Given this list of marker genes NUDT21, ACSBG1, RBM34, MMD, CLK4, CCNB1IP1, VAMP7, LINC01011, PHIP, H2AC6, ANKRD13A, PURA, PTMA, DHX29 (DExH-box helicase 29), UBE2D2, XK, PPP4R3B, GPR160, ABCE1, SNORD33, ERH, ZBTB4, GTSCR1, CLEC2D, UBP1, SH3BGRL2, HECA, SOX4, RBM27, TMEM123, HIGD1A, ARL6IP5, UBE2V2, NELL2, CCDC65, DLEU1, ANAPC16, CYP4V2, CORO1C, STAP1, H2BC21, DOCK11, CBFB, ECHDC1, ANKRD46, ZC3H11B, ZBTB8OS, C1orf198, HPF1, CHSY1, TLK1, MTPN, KLHL9, DIAPH2, OSBPL11, CFAP36, SNORD62B, MTF2, ARB2A, NUCKS1, CREBRF, PIGY, RNF11, DENR, STRADB, PSMA3, PAIP2, NKRF, TBPL1, DEK (NCBI Gene Id 7913), NRGN, RDH11, AQP10, FBXO33, ATP9A, ANKRD12, PTPN22, FAXDC2, MRPL42, TC2N (tandem C2 domains, nuclear), CEP20, PPP1R2, CAVIN2, ING3, RNF138, MPL, MEX3C, C2orf88, OPTN, TMEM14B, NT5M, MRPS28, ITGAE, INPP4B, RGS18 (NCBI Gene Id 92122), MTDH, FEZ2, RNASEH2B, CDKN2AIP, H2BC11, CELA1, IRF2BP2, GYPC, TOMM7, SPAST, ANAPC10, HSD17B12, AMD1, CABP5, ALOX12, CPD, ARFIP1, RGS10, ATG5, NAP1L1, MRPL3, IDI1, COPG2 (NCBI Gene Id 80038), COPS8, YPEL5, METTL23, MTURN, ARPC5, PCMT1, GUCY1A1, ANTXR2, PGRMC1, DIPK2A (NCBI Gene Id 205428), YEATS4, NDUFV2, RTRAF, ALG6, SNORD32A, ITGB5, MTX2, MFSD6, CTDSPL, TREML1, H3C10, PLEKHA8P1, GASK1B, LAX1, C1GALT1C1, RAD21, DYNLL1, OSTM1, PLCL2, TBC1D15, G3BP1, RPL15, YIPF4, SRBD1, MRPL21, PTPN12, CDV3, NMD3, LAPTM4B, PIK3R1, TMEM126A, SRSF1, TPM1, BCLAF1, RYBP, COPB1, TMEM158, BBOF1, GMPR, HBD, SLC39A8, HMGN4, LARP7, CCDC34, PCDHGB6, EPC1 (NCBI Gene Id 80314), VDAC3, ORC3, NT5C3A, CD8B, LEPROTL1, UBQLN1, VRK1, SDHAF3, RAB10, MAX, SCGB1C1, RBBP7, PSMA4, THOC7, GTF3A, PRPF18, PHAX, PRKAB2, TBK1, RAB21, SPC25, BMI1, ASB8, TIMM9, MFHAS1 (NCBI Gene Id 9258), LIMS1, ZNF189, CCSER2 (coiled-coil serine rich protein 2), VASP, SNORD8, UBE2Q2, CLDN5, PTGER4, CCDC91, TCF12, LRBA, RIT1, YBEY, STAG2, SNCA, CHD9, ADK, GNA12, SAP18, CDC23, FKBP3, SOD1, INTS8, NFIB, CNOT7, ABCC3, MYL4, JKAMP (NCBI Gene Id 95097), PTEN, TMED5, HBG2, SRP72, PSMA2, ACRBP, VWF, ENSA, BEX3, SPARC, NXT2, SNORD48 (small nucleolar RNA, C/D box 48), ARL8B, BCL2, MAP3K1 (NCBI Gene Id 4214), ALG5, MRPL47, ST8SIA4, GALNT1, H2BC9, SERINC1, MEIS1 (Meis homeobox 1), ZFAS1, AGFG1, NOSIP, UBE2E1, MMADHC, GOPC, IVNS1ABP, HBA1, ATP6V1G1, OSBPL8, H4C8, INTS6, MAST4, SAMD14, UBLCP1, TMEM14A, SERP1, CCDC90B, NUP88 (NCBI Gene Id 4927), TSPAN9, SMOX, ISCA1, NUCB2 (nucleobindin 2), EIF4G2, HMGB1, TP53INP1, PDCD10, RCAN1, TMT1A, BCL2L1, H2AC11, PIM1, TNPO1, RPS3A, MTMR6, FRMD3, GFM1, NPTN, PPP1R14A, RIMOC1, GIN1, YWHAH (NCBI Gene Id 7533), ETF1 (eukaryotic translation termination factor 1), RETREG1, CAST, MAT2B, MARCHF7, ZNF559, CGRRF1, BMP6, IGF2BP2, TSTD1, TNFSF4, CD3G, SSBP1, KLRC2, GLRX, CD226, MYLK, MRPS35, DNAJC15, FUNDC1, FRYL, FOXN3, HBA2, ABLIM3, PI4K2B, SLC35B3, CAPN1-AS1, CLIC4, AKAP11, ZNF17, STOM, N4BP2L2 (NEDD4 binding protein 2 like 2), NSA2, BAX, TBCA, KIF2A, DCAF12, EMC3, FLI1, GIMAP2, POC1B, ZC3H15, KIFC3, SELENOT, EIF1AX, NDUFAB1 (NCBI Gene Id 4706), NGDN, MRPL13, C1GALT1, DNM3, NUP54, CAMLG, NCK2, UBQLN2, PSMD14, RB1CC1, F13A1, DAB2, C6orf62, DMTN, WTAP, TAX1BP1, TAPT1, HPGD, CCNG1, CHM, PRORP, ERGIC2, SUZ12, PTCRA, DNAJB9, C12orf76, TNNC2, TM9SF2, KLHL28 (NCBI Gene Id 54813), FHL1, RIOK2, OSBP2, PSMC6, DPY30, RPL34, AKAP7, CLEC1B (NCBI Gene Id 51266), ACVR1 (activin A receptor type 1), ZCCHC7, RPS6KB1, IFRD1, RNA5S9, UCHL3, ADD3, NACA4P, LCLAT1, FHL2, TSC22D2, PDLIM1, TSC22D1, CENPK, BMPR2, COX7A2L, MFAP1, ZNF318, MAP3K7CL, PCMTD1, UGCG, SNORA12 (NCBI Gene Id 677800), PTGS1, RPA1, GPBP1, CCDC6, PROS1, GPR183 (G protein-coupled receptor 183, NCBI Gene Id 1880), MORF4L1, RNY1, EBAG9, PRNP, PIP4P2, TMEM140, ZFAND1, ITGB3, LAMP2, PAQR8, TUBA3D, PRDX6, ESAM, AHCTF1, ASAP2, SLITRK4, RAB11A (RAB11A, member RAS oncogene family), SEC62, IRF2BPL, CALD1, H2BC5, PTGES3, MSANTD3, H3C7, SRSF3, SMC2, MGLL, BAZ2B, H3C14, MAP3K7, SP3, NCK1, SINHCAF, EEF1B2, TMEM30A, ADPRM, LEPROT, MFSD1, GTF2F2, GNB5, GRB14, here is a description of the gene set: species: Homo sapiens Human Gene Set: THAKAR_PBMC_INACTIVATED_INFLUENZA_AGE_21_30YO_RESPONDERS_28DY_UP Genes up-regulated in peripheral blood mononuclear cell 28d vs 0d in young adults (21-30) (responders) after exposure to Inactivated influenza vaccine, time point 28D To elucidate gene expression pathways underlying age-associated impairment in influenza vaccine response, we screened young (age 21-30) and older (age >= 65) adults receiving influenza vaccine in two consecutive seasons and identified those with strong or absent response to vaccine, including a subset of older adults meeting criteria for frailty. PBMCs obtained prior to vaccination (Day 0) and at day 2 or 4, day 7 and day 28 post-vaccine were subjected to gene expression microarray analysis. We defined a response signature and also detected induction of a type I interferon response at day 2 and a plasma cell signature at day 7 post-vaccine in young responders. The response signature was dysregulated in older adults, with the plasma cell signature induced at day 2, and was never induced in frail subjects (who were all non-responders). We also identified a mitochondrial signature in young vaccine responders containing genes mediating mitochondrial biogenesis and oxidative phosphorylation that was consistent in two different vaccine seasons and verified by analyses of mitochondrial content and protein expression. These results represent the first genome-wide transcriptional profiling analysis of age-associated dynamics following influenza vaccination, and implicate changes in mitochondrial biogenesis and function as a critical factor in human vaccine responsiveness. from publication Thakar J, Mohanty S, West AP, Joshi SR, Ueda I, Wilson J, Meng H, Blevins TP, Tsang S, Trentalange M, Siconolfi B, Park K, Gill TM, Belshe RB, Kaech SM, Shadel GS, Kleinstein SH, Shaw AC (PMID 25596819)